Given this list of marker genes Parp12, Parp2, Parp6, Parp1, Parp11, Parp3, Parp16, Tnks (NCBI Gene Id 97475), Tnks2 (tankyrase, TRF1-interacting ankyrin-related ADP-ribose polymerase 2), Parp8, Parp10, here is a description of the gene set: The ADP-ribosylation by a protein of one or more of its own amino acid residues, or residues on an identical protein. species: Mus musculus Mouse Gene Set: GOBP_PROTEIN_AUTO_ADP_RIBOSYLATION